The following is a description of a gene set: studied in species Mus musculus Statin pathway Mouse Gene Set: WP_STATIN_PATHWAY, and this is the list of marker genes: Apoa1, Cyp7a1, Ldlr, Abca1, Lipc, Lpl, Apoa4, Soat1, Apoc1, Lcat, Apoc2, Hmgcr, Lrp1, Mttp, Pltp, Apoc3, Dgat1, Apoe, Scarb1